The following is a description of a gene set: Ankyrins are a family of adaptor proteins that couple membrane proteins such as voltage gated Na+ channels and the Na+/K+ anion exchanger to the spectrin actin cytoskeleton. Ankyrins are encoded by three genes (ankyrin-G, -B and -R) of which ankyrin-G and -B are the major forms expressed in the developing nervous system. Ankyrins bind to the cytoplasmic domain of L1 CAMs and couple them and ion channel proteins, to the spectrin cytoskeleton. This binding enhances the homophilic adhesive activity of L1 and reduces its mobility within the plasma membrane. L1 interaction with ankyrin mediates branching and synaptogenesis of cortical inhibitory neurons.<br> Reactome Pathway: Interaction between L1 and Ankyrins part of: L1CAM interactions studied in species Homo sapiens, and this is the list of marker genes: ACTB, SPTBN1, SCN5A, KCNQ3, SCN9A, ANK1, SCN11A, SCN1B, SPTBN2, SCN2A, L1CAM, SCN2B, ANK3, NRCAM, SCN1A, SPTA1, SPTBN5, ACTG1, SPTBN4, SPTAN1, NFASC, SCN10A, SCN3A, SCN7A, SPTB, ANK2, SCN4B, KCNQ2, SCN3B, SCN4A, SCN8A